The following is a description of a gene set: Human Gene Set: HP_ELEVATED_BRAIN_CHOLINE_LEVEL_BY_MRS An increase in the level of choline-containing compounds in the brain identified by magnetic resonance spectroscopy (MRS). studied in species Homo sapiens Elevated brain choline level by MRS, and this is the list of marker genes: IBA57, CNP, GRM7, PSAP, NAXE, NFU1, NGLY1, CYP27A1, NDUFAF6, GALC